The following is a description of a gene set: A G protein-coupled receptor signaling pathway initiated by a neuropeptide binding to its receptor on the surface of a target cell, and ending with the regulation of a downstream cellular process. Human Gene Set: GOBP_NEUROPEPTIDE_SIGNALING_PATHWAY studied in species Homo sapiens, and this is the list of marker genes: GPR37, GNAQ, PMCH, NPPB, TENM1, GALR3, RXFP3 (NCBI Gene Id 51289), GPR171, PTH2, TAC3, PYY3, SSTR4 (somatostatin receptor 4), PTGDR2, NPW, CARTPT, PDYN, QRFP, GALP, SSTR5, NPY4R, NPSR1, OPRL1, GALR1, NTS, SCG5, OPRM1, MCHR2, NXPH4, CYSLTR1, HCRTR1, SORCS2, GPR149, KISS1R, GALR2, GLRA2, NPBWR2, GRP, UTS2R, GAL, NPBWR1, NPY1R, NMUR2, GPR83, PCSK1N, RELA, SORCS3, PROKR2, GPR143, NPPA, LTB4R, NPY5R, OPRD1, OPRK1, ECRG4, ADCYAP1, PROK2, NPFF, SORL1, CMKLR2, PRLHR, NMS, CPE, NMB, MC2R, HCRT, MCHR1, CYSLTR2, PNOC, SSTR2, NPY4R2, PENK, GLRB, TAC1, AGRP, NMBR, NMUR1, GRPR, NPVF, RXFP4, GPR84, HCRTR2, NPS, PROKR1, UCN, NPFFR2, NXPH3, SSTR3, SORT1, LTB4R2, PPY, BRS3, QRFPR, NXPH2, SORCS1, ECEL1, NPY2R, CCKBR (cholecystokinin B receptor), PYY, NMU, GPR139, RAPGEF2, POMC, NPY, SSTR1, NTSR2, NPY6R, CRCP, NPB, GLRA1 (NCBI Gene Id 2741), TYRO3, NTSR1, NPFFR1